Given this list of marker genes IREB2, CDKAL1, RSAD2, POLE, ACO2, BRIP1, DNA2, NFU1, NDUFS1, RTEL1, DDX11, NUBPL, NDUFV1, ELP3, ACO1, NDUFS2, NUBP2, REV3L, DPYD, SDHB, CDK5RAP1, NUBP1, ERCC2, PPAT, POLR3F, CIAPIN1, DPH1, NTHL1, CIAO3, TYW1B, NDUFS8, EXO5, PRIM2, LIAS, RSAD1, POLD1 (DNA polymerase delta 1, catalytic subunit), DPH2, ABCE1, ISCA2, MUTYH, TYW1, MOCS1, ETFDH (electron transfer flavoprotein dehydrogenase), NDUFS7, METTL17, here is a description of the gene set: studied in species Homo sapiens Human Gene Set: GOMF_4_IRON_4_SULFUR_CLUSTER_BINDING Binding to a 4 iron, 4 sulfur (4Fe-4S) cluster; this cluster consists of four iron atoms, with the inorganic sulfur atoms found between the irons and acting as bridging ligands.